Given this list of marker genes FN1, SLC6A8, COL2A1, SLC16A2 (solute carrier family 16 member 2), RECQL4, SCNM1 (sodium channel modifier 1), TMEM94, here is a description of the gene set: studied in species Homo sapiens Human Gene Set: HP_UNDERFOLDED_HELIX Underfolded helix Underdevelopment of the helix that either affects the entire helix, or is localized.